Given this list of marker genes TERB1, TERF2IP, XRCC6, STN1, POT1, ACD, TERF1, TERF2, TEN1, RIF1, CTC1, TINF2, XRCC5, TERT, here is a description of the gene set: A complex of DNA and protein that seals the end of a chromosome. The telomeric repeat DNA consists of simple tandemly repeated sequences specific for each species. Typically one strand is G-rich and the other C-rich. The G-rich strand forms a 3'-terminal overhang, the length of which varies with species. The single strand overhang is bound by a variety of proteins, including telomere capping proteins that bind to the single-stranded DNA and seal the telomeric loop. Human Gene Set: GOCC_CHROMOSOME_TELOMERIC_REPEAT_REGION species: Homo sapiens